Given this list of marker genes Fos, Myh10 (myosin, heavy polypeptide 10, non-muscle), Mir24-1, Jmjd6, Slc17a8, Vstm4, Lamb2, Atoh7, Rom1, Tulp1 (NCBI Gene Id 58863), Arsg, Rdh13, Hes1, Tgfb2, Barhl2, Slc1a1, Cfh, Casz1, Nphp4, Lama1, Usp45, Tgif2, Bhlhe23, Apc, Six3, Sox9, Ntrk2, Dtnbp1, Gdf11, Ndp, Actl6a, Trpm1, Mdm1, Neurod4, Alms1, Bbs1, Bmpr1b, Nfix, Xrn2, Tcirg1, Arl6, Gnat2, Large1, Celf4, Miat, Mir27a, Vax2os, Irx6, Pax6, Nrl, Sdk2, Bhlhe22, Notch1, Ptf1a, Atp8a2, Dll1, Prox1, Lif, Rhoj, Lpcat1, Cacna1f, Pdgfb, Dio3, Pde6b, Slc38a8, Pdgfra, Vax2, Ikzf1, Ihh, Cdon, Rp1, Mfsd8, Tmem135, Fjx1, Nrp1, Mir183, Nphp1, Dll4, Ahi1, Elp6, Prom1, Rbp4, Clcn2, Vsx2, Prph2, Hipk1, Rd3, Chd7, Mfsd2a, Thrb, Zhx2, Psen1, Per1 (NCBI Gene Id 18626), Gnb1, Gpm6a, Lamc3, Fat3, Slc4a7, Calb1, Rorb, Mir182, Bsg, Acvrl1, Rpgr, Rp1l1, Bbs4, Hps1, Rpgrip1l, Med1, Mir218-2, Cabp4, Fzd4, Pou4f2, Rrm1, Ush1c, Mir124a-1, Bbs10, Nfia, Cyp1b1, Thy1, Tub, Lhx2, Lrp5, C3, Crb2, Ache, Crx (cone-rod homeobox), Hif1a, Smarcd3, Dram2, Pdgfrb, Hcn1, Rs1, Grk1, Nr2e3, Sox8, Hipk2, Rho, Pde6a, Agtpbp1, Mir23b, Ptprm, Mir96 (NCBI Gene Id 723886), Uchl3, Tgfb1, Dcx, Cfd, Pax4, Ttc8, Nfib, Tbc1d32, Dlx1, Stat3, Naglu, Neurod1, Impg2, Cep290 (NCBI Gene Id 216274), Foxn4, Clic4, Pde6c, Samd11, Pfdn5 (NCBI Gene Id 80400), Nectin1, Col4a1, Atp2b4, Mir124a-2, Cntf, Tgif1, Mir24-2, Sdk1, Casp2, Ski, Mir23a, Slc4a5, Bax, Man2a1, Tspan12, Irx5, Scaper, Crb1, Pax2, Ttll5, Grm6, Acvr2b, Rpe65, Lrp6, Mertk (MER proto-oncogene tyrosine kinase), Vsx1, Samd7, Ret, Opn4, Nectin3, Hpca, Cldn19, Megf11, Gnat1 (NCBI Gene Id 14685), Serpinf1, Sox2, Rpgrip1, Cln8, Mfrp, Lhx1, Zfp513, Ptn, Cnga3, Prdm1, Max, Dscam, Arhgef15, Nr2e1, Mir218-1, Mir27b, Dlx2, Bmpr2, Rpl24, Tfap2b, Grn, here is a description of the gene set: species: Mus musculus Mouse Gene Set: GOBP_RETINA_DEVELOPMENT_IN_CAMERA_TYPE_EYE The process whose specific outcome is the progression of the retina over time, from its formation to the mature structure. The retina is the innermost layer or coating at the back of the eyeball, which is sensitive to light and in which the optic nerve terminates.